The following is a description of a gene set: Genes predicted to be targets of miRBase v22 microRNA hsa-miR-548aq-5p in miRDB v6.0 with MirTarget v4 prediction scores > 80 (high confidence targets). studied in species Homo sapiens from publication Chen Y, Wang X (PMID 31504780) Human Gene Set: MIR548AQ_5P, and this is the list of marker genes: PTBP3, GULP1, S1PR1, PRKG1, C3orf38 (NCBI Gene Id 285237), FGL2, NCKAP1, PPARG, MAST4, SIX4, LRRC4B, SRSF6, DYNC1LI2, TRUB1, APPBP2, CBFB (core-binding factor subunit beta), OGFRL1, TTC19, EEA1, ZNF652, NAA30, MGARP, PCDH11X, MAML1, LRRC7, SOX5, RRAGD, PPP1R27, ADGRB3, CTNNA3, UNC80, MMUT, PROSER1, CBX3, MMP16, MTFR1, TRAM1, GPR155 (NCBI Gene Id 151556), ABCA5, TP53INP1, NUP54, SDE2, PPEF2, CISD2, TIFAB, SFMBT1, ANKRD26 (ankyrin repeat domain containing 26), AHSA2P (activator of HSP90 ATPase homolog 2, pseudogene), LPP, AP1AR, TFDP3 (NCBI Gene Id 51270), SMAD9, DPY19L3, AIDA (NCBI Gene Id 92615), LVRN, LRRTM3, COL11A1 (collagen type XI alpha 1 chain), SERINC5, UTP3, SYTL5, ODAPH, CARF, RPS6KA5, BRWD1, TMED7, RHPN2, NTF3, IGF1, CD163, ZBTB41, ZRANB2, RGPD8, SRSF3, TXLNG, ARK2N, TRIM9, SCN8A, CSNK1D, RORA, MBIP, PGRMC2, EVI2A, ADAMTS1, GOPC, CCSER1, LARP4, GPSM2, RALA, ACADL, HOXD13, MFSD8, STXBP5, PDCD5, C5orf24, RNF138, HIPK1, DUS4L, DCDC2, CACUL1, CCDC117, ZNF454, PAQR9, ZBTB25 (NCBI Gene Id 7597), ELL2, CAMLG, GABPA, RIC1, ZNG1B, SPOCK3, ZBTB11, MECP2 (NCBI Gene Id 8274), IGF2BP3, PLEKHH2, GPD2, C6orf120, WDR7, PDE1C, BEND7, TOLLIP, PTPRG, ETF1, ZNF492, ZC3HAV1L, DNAJB14, CLVS2, REV3L, SETD2, MIGA1 (mitoguardin 1), TMTC3, PPP5C, ACVR2B, WDR26, XPNPEP1, SERINC3, ZNG1C, GSTCD, NRXN1, SYNM, RMND5A, ZDHHC15, DIAPH3, ALG11, PAPOLG, ITGB6, FYB2, SEC22C, LMCD1, ATP11A, SH3D19, KLRD1, LACTB2, ZNF148, PCDH11Y, WDR47, CCP110, ATXN7L1, ACAT2, ARL13B, FBXL3, ZNF486, MAP9, FRMD5, HLTF, GATM, LCOR, SCML2, C21orf91, IGSF3, AGTR1, NOTUM (NCBI Gene Id 147111), KLF10, TMEFF2, TLCD4, KLF8, SCN1A, FOXG1, ABI3BP, TTC13, SCARF1, GPATCH11, PTGFRN, RAP2A, MED6, ASB3, CLDN12, GRID2 (NCBI Gene Id 2895), LANCL1, RAP1A, ITGAV, SAMTOR, ME1, CNTN1, SKIDA1, EXOC5, SACS, BTF3L4, BBX, MIER3, GUCY1A2, PAX5, DDIT4, SMAD5, FAM133A, TPM3, ADAM30, RICTOR, ZNG1F, YIPF5 (Yip1 domain family member 5), CLVS1, FAM135A, GUCY1B1, METTL8, TMTC1, ERC2, EPHA3, PRELID2, METTL6, CFAP44, FAM111A, SLC30A5, RAB8B, ZEB2, KL, DTWD2 (NCBI Gene Id 285605), PTPRR, ANKRD10, CSGALNACT2, FLRT3, CCDC50, GPR85, MMD (NCBI Gene Id 23531), EIF2AK2, ZNF680, KPNA4, CHN1, GLIPR1, ZBTB44, GRM5, TBCK, NOTCH2 (NCBI Gene Id 55574), BBS10, CCDC179, BCL2L2, GABRA4, UGDH, NEDD4L, SGIP1, ARID2, MFN1, MAP4K4, HNRNPDL, PRRC1, SREK1, MINDY2, KLF7, RETREG1, SMG1, RGPD5, KCNJ3, CA8, CLCN4, MDFIC, SPATA6L, ZBTB10, RASSF8, PCLO, MAGT1, ARMCX3, CCNG2, GPALPP1, SESTD1, ADAM22 (ADAM metallopeptidase domain 22), ZNF747, NDFIP2, LSAMP, TRPC1, ACBD5, DNAJB4, LRP1B, FIGN, HMBOX1, UGT8, CFDP1, WAPL, CHRNA7, GRM7, HDAC9, MARCHF6, SLCO5A1, CIAO2A, RGS7BP, BRWD3, HECA, CERS6, ACTN4, STEAP2, GRIP1, ZFAND5, TMEM135, MZT1 (mitotic spindle organizing protein 1), PRKAG2, SUMF1, KIF20B (NCBI Gene Id 9585), NAV2, SSR3, UEVLD, ADH5, PLEKHG1, AQP3, MBNL2, AFTPH, DOLPP1, ZNF326, BTG3, FNDC3B, TRIM2, ARFRP1, RESF1, ZBTB20, RNF149, GSE1, MCF2L2, KIAA1586, SCAMP1, KRT28, PREX2, NEGR1, ZNG1E, RHOQ, ZDHHC2, FSBP, DENND1B, PHYHIPL, PRKAA1, ANAPC1, NFKB1, PRPF39, DEFA6, SPDYE1, PITX2, SLC4A7, KATNBL1, ARRDC4, CD99, SDF4, RAB27B, CCNB1, NOS2, CEP350, PDE4D, LATS1, ZNG1A, GAPVD1, TMEM255A, ATXN2, HOOK3, ARL6IP6, GPC6, SEC24A, SNX16, SLAIN1, SPAG9, BNIP3, MEX3D, UBA6, TFAM, EDIL3, ZDHHC21, TMEM167B, LCTL, NUP160, SLC24A3, SF3A1, MIER1, PDZRN4, MTMR6 (NCBI Gene Id 9107), RGPD4, ACBD3, CHST7, HOMER1, AFDN, DCUN1D5 (NCBI Gene Id 84259), SCN3A, RAD54B, GCC2, CHST9, FZD3, OAZ1, MTA1, MYCN, COMMD3-BMI1, IKZF2, ZNF608, IKBIP, CFL2 (cofilin 2), JARID2, SH3BGRL, BMI1, UBE2A, NRG4, SNX30, NUP50, ZNF559, RBBP8, NDC1, B3GALT5 (beta-1,3-galactosyltransferase 5), FAM199X, MAST3, PPP1R2, SENP1, GASK1A, SRP9, MBNL3, SFT2D1, SDC2, PIWIL3, FZD5, TBCA, CRACD, BOD1L1, RNF217, CRIPT, AK3, RC3H1, EPB41L5, DAAM1, PSMC2, URI1, ONECUT2 (one cut homeobox 2), CAPN2, FMNL2, ADAMDEC1, NFAT5, PROK2, PRP4K, SAMD8, FNIP2, SNAP91, HTR2C, LACTB, FZD7, SANBR, FEM1C, C11orf87, DUSP7, FGD4, PPHLN1, RO60, CYBRD1, RIMOC1, SECISBP2L, TMEM200A, CCDC47, MTF1, CMPK2, RFC3, FAM221A, ZNF792, BTG2, SLU7, MEIS2, PRPF40A, STYX, LIN7A, CDK6, POU2F1, TRA2B, TMEM65, NUMB, NR2C1 (nuclear receptor subfamily 2 group C member 1), GTF3C3, LMX1A, RFX7, CCNY (cyclin Y), CAMSAP2, ZCCHC8, GABPB1, PPP1R9A, PGAM1, DHRS1, THSD7A, NAT1, CEP120, MIDEAS, CACNA2D3, GNAQ, PRKAA2 (protein kinase AMP-activated catalytic subunit alpha 2), ANGEL2, ZNF503, TNFRSF21, TCF12 (transcription factor 12), RGPD6, GOLGA6L2, POLR2H, FGFR1OP2, C9orf40, DYNC1I2, ANKRD22